The following is a description of a gene set: Detoxification pathway genes down-regulated in enterocytes of transgenic mice expressing SV40 T antigen. species: Mus musculus from publication Sáenz-Robles MT, Toma D, Cantalupo P, Zhou J, Gong H, Edwards C, Pipas JM, Xie W (PMID 17334401) Mouse Gene Set: SAENZ_DETOX_PATHWAY_AND_CARCINOGENESIS_DN Toxic compounds such as carcinogens are removed from the body by the action of a series of detoxifying enzymes and transporters expressed in the liver and the small intestine. We have found that intestinal epithelial cells expressing the SV40 large T antigen (TAg) contain significantly lower levels of mRNAs, encoding several drug metabolizing/detoxifying enzymes and transporters compared to their non-transgenic littermates. In addition, TAg blocks the induction of these mRNAs by xenobiotics. The repression depends on an intact LXCXE motif in TAg, suggesting that inactivation of the retinoblastoma (Rb) family of tumor suppressors plays a role in the process. These results imply that a functional Rb pathway in the intestine is necessary for the expression of the detoxification system used to clear carcinogens, and suggest that loss of this tumor suppressor might alter susceptibility to chemical injury. In addition, the effect of TAg on the detoxification pathway appears to be tissue-specific, as its ectopic expression in the liver failed to suppress the P450 enzymes. The TAg-mediated suppression of drug metabolizing/detoxifying enzymes may have broad implications in the metabolism and mechanism of action of both carcinogens and prescription drugs., and this is the list of marker genes: Cyp2c50, Cyp3a13, Cyp4b1, Gstt1, Cyp4f14, Cyp2b9, Cyp2c40, Gstk1, Cyp3a11, Vdr, Cyp3a25, Cyp2d10 (NCBI Gene Id 13101), Cyp2b10 (cytochrome P450, family 2, subfamily b, polypeptide 10), Gsto1, Ackr3, Cyp2d9, Abcc2, Cyp2c29, Cyp2c65, Slco2a1